Given this list of marker genes KIR3DS1, LILRA4, LILRA2, LILRA5, KIR3DL1, LILRB1, LILRB4, KIR2DS5, LILRB2 (NCBI Gene Id 10288), KLRF1, MR1, CTSH, LILRA3, CD160, LILRA6, LILRB5, LILRB3, LILRA1, here is a description of the gene set: Combining with an MHC class I protein complex to initiate a change in cellular activity. Class I here refers to classical class I molecules. Human Gene Set: GOMF_MHC_CLASS_I_RECEPTOR_ACTIVITY species: Homo sapiens